Given this list of marker genes Tsc22d2, Trpc3, Map3k9, Fgd4, Ythdc1, Slc25a32, Ubxn7, Mybl1 (NCBI Gene Id 17864), Rerg, Ahr, Heph, Nfatc3, Sgip1, Kcnh5, Pdgfrl, Stab2, Psma2 (proteasome subunit alpha 2), Npnt, Dhx32, Iqck, Hnrnpd, Csnk1g3, Ppp1r14bl, Etfbkmt, Ssr3, Ccn3, Errfi1, Kdm6a, Csmd3, G2e3, Pitpnc1, Zfp182, Tmed5, Vcl, Pla2g4e, Zfp711, Olig3, Tbpl2, Zfp984, Fam110c, Poglut2, Ms4a4b, Snx6, Slc25a40, Ehf, Dab2ip (NCBI Gene Id 98996), Zfp268, Cdc37l1, Prr16, Slc17a8, Bmp2k, Tshz1, Ube2q2 (NCBI Gene Id 76838), Zfp367, Lnx1, Eef2kmt, Cdkl1, Grhl1, Fstl4, Cyld, Tmcc1, Nr1h5, here is a description of the gene set: Mouse Gene Set: MIR_1A_2_5P species: Mus musculus from publication Chen Y, Wang X (PMID 31504780) Genes predicted to be targets of miRBase v22 microRNA mmu_miR_1a_2_5p in miRDB v6.0 with MirTarget v4 prediction scores > 80 (high confidence targets).